The following is a description of a gene set: Human Gene Set: GSE12845_IGD_POS_VS_NEG_BLOOD_BCELL_DN Genes down-regulated in comparison of IgD+ B cells versus IgD- B cells. B cells from human tonsil and blood were sorted using flow cytometry. The human samples were processed immediately ex-vivo using markers for known B cell subsets. studied in species Homo sapiens from publication Longo NS, Lugar PL, Yavuz S, Zhang W, Krijger PH, Russ DE, Jima DD, Dave SS, Grammer AC, Lipsky PE (PMID 19023113), and this is the list of marker genes: NCF2, MANF, IGKV1-5, ANXA5, SIL1, VDAC3, RRM2, IGLV1-44, MGLL, AURKB, ACTG1, NUCB2, ACO2, ZNF706, PIK3C2A, ZBTB32, TMEM184B, SPATS2, SEC61B, ATP6V1C1, BLMH, HSP90B1, MAGOH2P, RMDN3, PPA1, SEPTIN11, MTX2, TAP1, SNU13, S100A10, SPCS1, NUDT4, GNG7, NTAN1, CDK5, RAD17, IGLV6-57, NFE2L3, MAD2L1, CAV1, SND1, CRELD2, BIK, FKBP11, SRGN, PABPC4, USO1, LANCL2, DECR1, RPN2, PREB, DIPK1A, NDUFAF1, TXN, SMAP1, CALM1, CCNB1, USP14, UBE2J1, MTHFD2, PLEKHB1, DNAJC3, SPCS3, TMEM208, IBTK, CCNE1, ORMDL2, PRDX4, TMED9, PCCB, TNFRSF17, CD86, TMED3, RUVBL1, CFLAR, GYG1, RBM3, PAPOLA (NCBI Gene Id 84718), JCHAIN, YWHAH, IGKV3-20, ANXA2P2, ANXA2, HMGN4, SLC27A3, PRKCD, CORO1C, DNAJC24, GOLPH3, TBL2, CMAHP, CALHM2, CSRNP2, JPT1, CALML4, PIGP, SHCBP1, ENO2, CDK4, BRIX1, ALG8, MTX1, SSR4, GSN, CDR2, IGLJ3, HSPA5, ATP1B3 (ATPase Na+/K+ transporting subunit beta 3), IFI30, RCBTB2, ADA, PDIA6, SEC13, DCPS, AP2S1, IDH2, MYDGF, JHY, BCL2L11, BRCC3, MGAT2, PPIB, INTS7, GUSBP11, FUCA1, PRDX1, CASP3, SEC14L1, DDAH2, ACSF2, IGLV4-60, GPX7, ALG9, MCM6, PDIA4, ARID3A, ETHE1, TUBB, CTSA, PSMG1, HIBCH, PTCH1, EHD3, PUS7, SEC61A1, TTC38, TFRC, FAS, MSRB2 (methionine sulfoxide reductase B2), GSPT1, OSBPL2, ATP5F1B, RUFY3, DYNLL1, CSRP1, HIGD1A, ACAT1 (acetyl-CoA acetyltransferase 1), GRN, RBBP8 (NCBI Gene Id 5932), IGKC, CAPRIN1, XBP1, LRRFIP2, MRPL12, RNF34, BFAR, PELO, FABP5, NCL, RETSAT, CAPN2, FAIM, LY96, IGLL3P, AKR1A1, MAN1A1, IGKV1D-13, CSF2RB, ATP1B1, KRAS, CD99, BET1, CORO7, ATP1A1 (ATPase Na+/K+ transporting subunit alpha 1), CEP97, RAB1A, PEBP1, BID, NEDD8, ANKRD36, EMC2, STK38, DLAT (NCBI Gene Id 1737), TRIB1, ANG, LGALS1